Given this list of marker genes CYGB, WNT4, F2, UCN, MMP7, MMP14, MIR21, ADAMTS14, MMP13, RCN3, PLOD3, SCX, MMP24, MIR29B1, AMELX, P3H2, RGCC, CTSS, SUCO, KLK6, ADAMTS3, SMPD3, MIR218-1, MMP27, COL6A1, MMP25, MIR92A1, IL6, P3H1, CTSL, MMP16, MRC2, CTSK, PRTN3, RUNX1, TNS2, MIR149, RAP1A, F2R, COL5A1, PEPD, TGFB3, VPS33B, MMP19, MMP21, EMILIN1, HIF1A, SERPINB7, ERRFI1, MMP2, VSIR, FOSL2, CST3, MMP1, NOTCH1, PRSS2, TRAM2 (NCBI Gene Id 9697), NPPC, SERPINH1, MMP9, LARP6, TRAPPC8, TMEM131, PRDX5, MIR145, MMP23B, FAP, CBX8, RETREG2, ADAMTS2, IL6R, PPARD, P3H3, SERPINF2, DDR2, ITGB1, TGFB1, MMP17, RETREG3 (reticulophagy regulator family member 3), MYB, C6orf89, MMP3, MMP12, NAGLU, ADAM15, MMP10, MMP20, MIR29A, CTSB, ID1, IHH, TNXB, MFAP4, MMP11, MMP15, FURIN, CREB3L1, TMPRSS6, MMP8, GOT1, ITGA2, CYP7A1, COL1A2, PCOLCE, MMP28, INHBA, CIITA, VIPAS39, P3H4, MMP26, BMP4, COL1A1, RETREG1, P2RX7, VIM, here is a description of the gene set: The chemical reactions and pathways involving collagen, any of a group of fibrous proteins of very high tensile strength that form the main component of connective tissue in animals. Collagen is highly enriched in glycine (some regions are 33% glycine) and proline, occurring predominantly as 3-hydroxyproline (about 20%). Human Gene Set: GOBP_COLLAGEN_METABOLIC_PROCESS species: Homo sapiens